Given this list of marker genes HLA-DRB1, CD1D (CD1d molecule), TLR7, DCP1B, CCR1, TLR8, TLR5, CD1B, CCR3, IRAK4, CD81, DCSTAMP, CD58, CARD14, CCL17, TAP1, FCER1G, TLR2, HLA-DMA, CARD8, DCTN2, FAS, LILRB4, TLR4, ADAM11, TLR6, TLR1, HLA-DQB1, MYD88, CD68, IRAK2, CD80, ADAMDEC1, NOD2, CD44, FCGR1A, HLA-DMB, FCGR2B, CD1C, CDC42, CCL22, FCGR2A, CD209, FCER1A, TRAF6, CCR5, HSP90B1, TLR3, RBMS1, TLR10, CD1A, TIRAP, CD74, TLR9, CD86, CCR2, ICAM2, here is a description of the gene set: The live vaccine strain (LVS) of Francisella tularensis is the only vaccine against tularemia available for humans, yet its mechanism of protection remains unclear. We probed human immunological responses to LVS vaccination with transcriptome analysis using PBMC samples from volunteers at time points pre- and post-vaccination. Gene modulation was highly uniform across all time points, implying commonality of vaccine responses. Principal components analysis revealed three highly distinct principal groupings: pre-vaccination (-144 h), early (+18 and +48 h), and late post-vaccination (+192 and +336 h). The most significant changes in gene expression occurred at early post-vaccination time points (<=48h), specifically in the induction of pro-inflammatory and innate immunity-related genes. Evidence supporting modulation of innate effector function, specifically antigen processing and presentation by dendritic cells, was especially apparent. Our data indicate that the LVS strain of F. tularensis invokes a strong early response upon vaccination. This pattern of gene regulation may provide insightful information regarding both vaccine efficacy and immunopathogenesis that may provide insight into infection with virulent strains of F. tularensis. Additionally, we obtained valuable information that should prove useful in evaluation of vaccine lots as well as efficacy testing of new anti-F. tularensis vaccines. Genes up-regulated in peripheral blood mononuclear cell 18hr vs 0hr in adults (22-54) after exposure to F. tularensis vaccine LVS, time point 18H from publication Fuller CL, Brittingham KC, Porter MW, Hepburn MJ, Petitt PL, Pittman PR, Bavari S (PMID 17349694) studied in species Homo sapiens Human Gene Set: FULLER_PBMC_F_TULARENSIS_VACCINE_LVS_AGE_22_54YO_18HR_UP